The following is a description of a gene set: Human Gene Set: GOCC_RIBONUCLEOPROTEIN_GRANULE studied in species Homo sapiens A non-membranous macromolecular complex containing proteins and translationally silenced mRNAs. RNA granules contain proteins that control the localization, stability, and translation of their RNA cargo. Different types of RNA granules (RGs) exist, depending on the cell type and cellular conditions., and this is the list of marker genes: MCRIP2, GHR, ANKRD34C, TRIM25, MEX3B, POLDIP3, BPI, PATL1, EIF4EBP2, DCP2, UBAP2L, EIF3B (NCBI Gene Id 8662), PAN2, HENMT1, CNOT8, MYH1, ZC3H12C, TBRG4, SARNP, SHFL, RPL6, TDRD9, ZC3H12A, SLC39A2, CTSH, DDX19A, UBAP2, FAM184A (family with sequence similarity 184 member A), TARDBP, AICDA, DDX6, NANOS3, MOV10L1, GIGYF2, PABPC1L2A, EIF2S1, PRRC2C, ANKRD34A, C9orf72, UPF1, AGO3, DYNC1I1 (dynein cytoplasmic 1 intermediate chain 1), DHX36, SERPINB1, PATL2 (PAT1 homolog 2), GTSF1, RPL28, BMAL1, HNRNPAB, ZC3H12D, YTHDC2, CNOT3, ARC, RPS4X, CNOT7, CNOT1, SQSTM1, DDX3Y, RC3H2, HELZ2, EID1, TUT4, ANKRD34B, PPP6R2, PABPC1L, EIF4G1, RNF135, CDK9, PUM1, HIPK2, FASTKD3, NXF1, MOV10, FASTKD5, INA, SNCAIP, KPNB1, SHB, TIAL1, HNRNPK, MFSD2A, STAU1, FASTKD1 (FAST kinase domains 1), RPLP0, AGO2, PABPC5, TDRD6, ZFAND1, APOBEC3H, TAF5L, CDC42, WTIP, LSM2, PSMA6, NOCT, PABPC4, CNOT2, ZFP36L1, LARP1 (La ribonucleoprotein 1, translational regulator), BARD1, TRIM5, NANOS2, IGF2BP2, SMN1, HSF1 (NCBI Gene Id 642255), HNRNPL, GABPB1, CARHSP1 (NCBI Gene Id 23589), LARP1B, FXR1, ZAR1L, TSTD1, PAN3, SNRPB2, G3BP2, PABPC4L, RPTOR, PABPC3, LSM14B, TDRD5, DHX30, SUMO1, YTHDF1, DYRK3, DDX28, EDC3, NBDY, SYMPK, NUFIP2, RBPMS, YTHDF3, SAMD4B, MEX3A, PNRC2, APOBEC3B, AJUBA, LSM6, DDX1, RPUSD4, TOP1, NCL, PIWIL1, DDX19B, RBFOX1, PIWIL3, PIWIL2, TUBB, CTSG, RPUSD3, LSM3, ROCK1, LARP4, ZFP36, HELZ, STAU2, FLG, APOBEC3G, ANG, LSM1, RBM20, DCPS, CLOCK (NCBI Gene Id 9575), IGF2BP1, FXR2, EIF4E, HNRNPU, DCP1A, PIWIL4, MCRIP1, TDRD7, DHX9, XRN1, YTHDF2, TIA1, DDX25, PSMA4, HAX1, CPEB1, PSMC2, LSM14A, MAP1LC3C, SNRPGP15, DDX3X, GARRE1, ZNFX1, POLI, SMG5, POLR2G, NYNRIN, VCP, FASTK, CNOT9, FMR1, TNRC6B, PABPC1L2B, KMT5B, SAMD4A, USP3, BTBD2, NFKBIZ, GRSF1, NSUN2, UHMK1, DIS3L2, SSB, ATXN2, PRKAA2, MAPT, ELAVL1, ACTB (actin beta), ISG20, AGO1, OGFOD1, CAPRIN1, CASC3, YBX1, DAZAP2, RBM4, PCBP1, ZC3H12B, SYNE1, HOXD10 (NCBI Gene Id 3236), FASTKD2, PSMC3, CELF1, TNRC6A, KHNYN, TRUB2, APOBEC3A, QKI, TUBA1A, EIF4E2, GRB7 (growth factor receptor bound protein 7), TRIM71, APOBEC3F, APOBEC3C, EXD1, EIF4A1, LIN28A, CIRBP (cold inducible RNA binding protein), RAC1, ZAR1, EIF4ENIF1, LSM4, UPF2, ASZ1, HABP4, AGO4, PQBP1, TDRD1, ATXN2L, EDC4, IGF2BP3, TRIM21, RPS6, RC3H1, LARP4B, SMN2, PNRC1, PUM2, IQGAP1, CMA1, MAEL, MBNL1, PSMA2, G3BP1, ENDOV, DCP1B, PABPC1, DDX4, APOBEC3D, RBPMS2, SMG1, LIMD1, CSDE1, SNRPG, PKP1, BTBD1, ROCK2, TNRC6C, TDRKH